Given this list of marker genes TNXB, RB1, EMILIN1, CHADL, EFEMP2, MIR29B1, COLGALT1, COL6A1, AEBP1, here is a description of the gene set: Any process that modulates the frequency, rate or extent of collagen fibril organization. species: Homo sapiens Human Gene Set: GOBP_REGULATION_OF_COLLAGEN_FIBRIL_ORGANIZATION